The following is a description of a gene set: species: Mus musculus Reactome Pathway: Negative feedback regulation of MAPK pathway part of: Negative regulation of MAPK pathway This event has been computationally inferred from an event that has been demonstrated in another species.<p>The inference is based on the homology mapping from PANTHER. Briefly, reactions for which all involved PhysicalEntities (in input, output and catalyst) have a mapped orthologue/paralogue (for complexes at least 75% of components must have a mapping) are inferred to the other species. electronically inferred by orthology from the curated human pathway, and this is the list of marker genes: Map2k1, Map2k2, Mapk3